The following is a description of a gene set: studied in species Homo sapiens Enlarged cisterna magna Increase in size of the cisterna magna, one of three principal openings in the subarachnoid space between the arachnoid and pia mater, located between the cerebellum and the dorsal surface of the medulla oblongata. Human Gene Set: HP_ENLARGED_CISTERNA_MAGNA, and this is the list of marker genes: SLC31A1, RAB18, EIF4A2, CSPP1, VRK1, CLP1, CSF1R, NFU1, DYRK1A, CTU2, TBCK, CNOT3, BANF1, EDEM3, APC2 (NCBI Gene Id 10297), NEK8, MAN2B1, KATNB1, SH3PXD2B, PITX1, PIGU, RAC1, NDUFC2, CPLANE1, SH2B1, SLC5A6, KIAA0586, ZFX, IL6ST, SLC35A2, NSD1, DPH5, OPHN1, VPS51, ALDH18A1, FOXC1, FBXL4, POLR2A, MAPKAPK5 (NCBI Gene Id 8550), COG1, POMT1, FLNB, POGZ, RNU12, FBXO28, PLCH1, EBF3, ALDH7A1, POMK, PMPCA, EXOSC8, PACS2, TIMMDC1, BRF1, OFD1, AHDC1, PLPBP, PI4K2A, PRX, SRPK3, ACADVL, AFF3, PMM2, CDH2, SUFU, RNU4-2